Given this list of marker genes REEP3, SLC6A4, MSRB3, KIF3C, SKIL, VPS50, POGLUT3, RCAN3, CSAD, TMEM255A, EYA3, LBR, SETDB1, PLEKHF2 (NCBI Gene Id 79666), ETNK1, NFATC3, TMEM132B, APOLD1, MXI1 (MAX interactor 1, dimerization protein), RIMS2, SP3, PRSS23, AMD1, COMMD2, RND3, RAB26, CACNA2D1, TBC1D15, PCDHGA8, G3BP2, MACIR, GUCY1A2, SKIDA1, RASA2, PFKFB3, AGK, CLINT1 (NCBI Gene Id 9685), NIBAN1, RBBP4, VIRMA, FNBP1L, SLC17A8, ZNF800, CFAP206 (cilia and flagella associated protein 206), CREBZF, REDIC1, KRAS (KRAS proto-oncogene, GTPase), GPR37, DHX15, PAPPA, UBA5, DTD2, C15orf40, AMBN, RNF138, ESCO1, WIPI2, ABCD2, RTKN2, TCP11L1, ETV5, SIAH1, SLC35A3, HIPK1, ATP11C, KLHL24, PCDH9, CXCL11 (NCBI Gene Id 6373), SPRED1, NPAT, EP300, TENM3, TLCD4, SOX9, WEE1, CPSF6, PHIP, SCCPDH, ATXN7, USF3, ZNF140, ROBO1, PPP2R2B, SLX4IP, CCDC18, DNAAF5 (dynein axonemal assembly factor 5), PTGER4, HDAC9, LYRM2, STAP1, PPM1E, TMX1, PCMTD1, CEP41, KANSL1, STRADB, MOSPD1, FOXP1, ANKRD13C, ALAD, NDFIP1, RICTOR, KIF21A, KBTBD11, SLC25A24, ZCCHC14, GRIA4, SYNPO2, ZNF518A, NAA25, CRTAP, FOXO3, CHD6 (NCBI Gene Id 84181), KLHL42, RAB33B, CLOCK, ZFY, HAPLN1, JPH1, SLC25A46, WNT16, GK5, ZNF503, UBE2K, ILF2, SLC36A4, OSTM1, YTHDF1, TBC1D8B, MARK1, VAPA, MGME1, SMAP2, JAKMIP2 (NCBI Gene Id 9832), PRKAA2, GAN, FGG, COX15 (NCBI Gene Id 1355), CCN2, JADE1, PRPF4, TTC13, VWA2, SEMA6D, RGS20, DENND6A, NLRP3 (NLR family pyrin domain containing 3), DGKH, MAP10, SLK, MMP12, GPC6, NCKAP1, CEP63, P4HA3, TMEM168, UVSSA, TCHH, SLC7A11, STXBP5, IKZF5, ZBTB21, ENPP5, SPOP, PKIA, TMPO, PAIP1, FANCF, ZNRF2, KLF11, DOK6, ALS2, ZNF426, LARP4, VGLL3, AP1S2, UBQLN1, ADCYAP1, KLF5, NIPA1, DNAJC27, RAB27B, IGSF3, VKORC1L1, ERC2, PHLPP1, YOD1, NIPBL, PGR, SPOPL, KLHL15, EEF1E1, RNF128, RAB6D, CDIN1, TAF4B, CCSAP, FLRT2, ARID4B, SOX11, TRPC3 (NCBI Gene Id 7222), MAGEH1, MS4A7, CYREN, EFR3A, PFN4, RAD21, ADH7, SSBP2, ELK4 (ETS transcription factor ELK4), HOOK3, FAN1, CCDC126, PALM3, KITLG, SPON1, SORCS3, FAT3, REPS2, BCLAF3, KLF12, FZD3, PDIK1L, ARHGEF7, ZBTB4, TMEM215, RAD54B, CTDSPL2, TMTC2, PAX9, RAB3C, PGAP1, HYCC2 (NCBI Gene Id 285172), CNTN1, MDM1 (Mdm1 nuclear protein), KCNA1, SGK3, CLIP1, TENM1 (NCBI Gene Id 10405), IGF2BP3, MDM2, U2SURP, DCUN1D1, MTMR6, TRHDE, C8orf44-SGK3, ARFIP1, PTP4A1, MED4, SALL4 (spalt like transcription factor 4), RCBTB1, ARFGEF3, RAPGEF6, TOR1AIP2 (NCBI Gene Id 64163), SP8, TSN, ATP2A1, MID1, RBM7, TRIM24, ESRRG, DENND4A, HCN1, PABPC4L, IL17RD (NCBI Gene Id 54756), HDHD2, DAAM1, SLC24A4, SLC25A5, ELOC, TSPAN2, CITED2, RTTN, RADX, GNG2, TMED7, ST7, ZNF780B, AKAP11, USP51, SCAF11, YME1L1, ARL5A, KIFBP, PROSER2, GALNT7, GPX8, NETO1, HSPA4L, MBD2, CCDC90B, GDA, ATOSA, DCAF8L1, DYRK1A, FAM149A, ESCO2, RNF180, CSGALNACT2, KCTD9, PARP11, AEBP2, TERF2IP, EPB41L5, RAB30, SSX2IP, ZBTB20, FAM199X, SLC7A14, KDM7A, RSPRY1, NEBL, CEP350, LPAR1, SLC25A21, UBR3, MGAT4A, SOS1, EHF, GMCL1, IL23A, GGCX, ZNF830, SRGAP2, MLLT3, BLOC1S6, SEC11C, CDK12, EAF1, CREBRF, C17orf100, SUB1, ZMYM2, PAPSS2, ZNF326, TUBB, STRN3, CASQ2, FGL2, RGS4, TXLNG, C22orf39, RHOBTB1, CLCN4 (chloride voltage-gated channel 4), CAV1, USO1, PPP4R2, HMGA2, PLCXD3, ABTB3, TBC1D4, PHC3, ACVR2B, UBP1, COL25A1, OCLN, CNTN4, ACVR2A, ZFX, NPAS3, TMEM167B, ARL6IP6, LAT2, TMEM69, PAIP2, PRM1, MINDY2, CDH6, RUNX1T1, PIWIL4, BCL6, MAP7, TMTC3, C1orf174, USP13, RSRC2, TGFBR1, RBPMS, RFX3, MATCAP2, LNX2, BNC2, CPSF7, PGRMC2, AZI2, ATXN1, CDYL2, BANK1, PPP2R3A, EXD2, GCFC2, TUBB2B, CNTNAP3B, FAR1, PATJ, TMEM33, LLGL1, CHL1, PROX1, ONECUT2, NADK, TAF4, ZBTB11, PRTG, CLVS2 (clavesin 2), PLOD2, MDFIC, PPP3CA, ZNF263, RASA1, CDKL1, ZZZ3, IGF1, FAM241A, KPNB1, DDI2, MCTP2, CLVS1, MIS18BP1, OPRM1, SEPHS2, BCLAF1, CSTF2, MAB21L1, FLRT3, CNOT6L, BPNT2, DTWD2, VAPB, IPP, LDLRAD4, HOOK1, FBXO15, FCHO2, ZIM3, DCLK1 (NCBI Gene Id 9201), GCNT1, CACNB4, GID8 (GID complex subunit 8 homolog), PREPL, AGTPBP1, PTGR3, DYRK2, FAM81A, PCDH15, RRAGC, SLITRK2, SERINC1, NMU, GALNT3, PSMC2 (NCBI Gene Id 5701), ZNF12, ATG12, POGLUT1, ZDHHC6, FRMD6, FAXC, PRKG1, CEP170, ACACB (NCBI Gene Id 32), CD1D, USP46, SLC24A1, ITGB1, HMGB1 (NCBI Gene Id 3146), LBH, RSL1D1, THAP2, ZNF557 (NCBI Gene Id 79230), EYA4, DENND5B, ST3GAL5, EIF2S1, PYGO1, ANKRD30A, RAG2, ESM1, FSTL5, ZFHX3, CDC14B, FGD4, GCN1, MKRN1, ACOT9, SPATA4, LARP7, CNTN3, GABRA4, TGFB2, HMGCR, ADH4, OSBPL11, AHR, INSC, MEIKIN, DNAH5, ITPR2, RLIG1, ELL2, NEK7, TP53INP1, LARP4B, CRLS1, ELMOD2, SRGAP1, PWWP3B, ATXN7L1, PWP2, SFMBT2, PDE6A, PPIE (NCBI Gene Id 10450), SEL1L (SEL1L adaptor subunit of SYVN1 ubiquitin ligase), MPRIP, KATNBL1, here is a description of the gene set: species: Homo sapiens Human Gene Set: MIR1305 Genes predicted to be targets of miRBase v22 microRNA hsa-miR-1305 in miRDB v6.0 with MirTarget v4 prediction scores > 80 (high confidence targets). from publication Chen Y, Wang X (PMID 31504780)